The following is a description of a gene set: Reactome Pathway: Mitochondrial protein import part of: Protein localization species: Mus musculus This event has been computationally inferred from an event that has been demonstrated in another species.<p>The inference is based on the homology mapping from PANTHER. Briefly, reactions for which all involved PhysicalEntities (in input, output and catalyst) have a mapped orthologue/paralogue (for complexes at least 75% of components must have a mapping) are inferred to the other species. electronically inferred by orthology from the curated human pathway, and this is the list of marker genes: Ndufb8, Hspd1, Coq2, Pitrm1, Atp5f1b, Fxn, Otc